Given this list of marker genes CPOX, POLG, LIG3, TYMP, RRM2B, MYO1H, here is a description of the gene set: Small intestinal dysmotility studied in species Homo sapiens Human Gene Set: HP_SMALL_INTESTINAL_DYSMOTILITY Abnormal small intestinal contractions, such as spasms and intestinal paralysis related to the loss of the ability of the gut to coordinate muscular activity because of endogenous or exogenous causes.